Given this list of marker genes Nek2, Adipoq, Ctc1, Rfc5, Gfer (growth factor, augmenter of liver regeneration), Pml, Mapk15, Pcna, Jade2, Map2k7, Gch1, Atr, Exosc10, Gja1, Terf1 (telomeric repeat binding factor 1), Nfatc1, Fgfr4, Acd, Hgf, Vegfa, Chek1, Rfc2, Meaf6, Jade1, Cct6a, Polg2, Fgf2, Terf2, Niban2, Dkc1, C3ar1, Fbxo4, Pdgfrb, Jade3, Arrb2 (NCBI Gene Id 216869), Cct5, Parn, Map3k4, Kcnk2, Camk2d, Nox4, Crhr2, Gnl3l, Ten1, Mapk1, Ddx39b, Tfdp1, Nppc, Pkib, Pak3, Htr2a (NCBI Gene Id 239184), Mapk3, Dnajc2, Egf, Pinx1, Tinf2, Rfc3, Chtf18, Cyp1b1, Pdgfb, Ptk2b, Dusp1 (dual specificity phosphatase 1), Hmbox1, Pot1a, Kat7, Smoc2, Dach1, Dcp2, Pot1b, Cct8, Tnks, Hnrnpu, Tcp1, Rfc4, Ing5, Xrcc5, Ctnnb1, Pif1, Wrap53 (WD repeat containing, antisense to Trp53, NCBI Gene Id 216853), Cct4, Ahr, Atm, Mapkapk5, Ccna2, Ptges3, Cct7, Rgcc, Hnrnpc, Cct3, Pdgfa, Wnt3a, Ing4, Chtf8 (NCBI Gene Id 214987), Src, Tnf, Sh2b1, Prkcq, Nek7 (NCBI Gene Id 98561), Terc, Pnkp, Rgn, Cdkn1a (NCBI Gene Id 12575), Trp53, Nat10, Hnrnpd, Tent4b, Ankrd1, Gsk3b, Aurkb, Prkd2 (protein kinase D2), Dscc1, Cct2, Stn1, here is a description of the gene set: Any process that modulates the frequency, rate or extent of DNA biosynthetic process. Mouse Gene Set: GOBP_REGULATION_OF_DNA_BIOSYNTHETIC_PROCESS studied in species Mus musculus